The following is a description of a gene set: Sensory perception of taste Human Gene Set: REACTOME_SENSORY_PERCEPTION_OF_TASTE studied in species Homo sapiens, and this is the list of marker genes: GNB1, CALHM1, TAS2R39, GRM1, SCNN1D, TAS1R1, TAS2R41, TAS2R43, TAS2R16, ITPR3, GNB3, SCN9A (NCBI Gene Id 93955), TAS2R3, CALHM3, TAS2R13, TAS2R38, TAS2R14, SCN4B, TAS2R40, GNG13, TAS2R10, TAS2R20, PLCB2, TAS2R31, SCNN1B, TAS2R8, TAS1R3, SCN1B, TAS2R46, TRPM5, TAS2R30, KCNJ2 (potassium inwardly rectifying channel subfamily J member 2), SCN2A, TAS2R1 (taste 2 receptor member 1), TRPM4, GRM4, SCNN1G, TAS1R2, SCN2B, SCNN1A, TAS2R4, SCN3A, GNAT3, TAS2R50 (taste 2 receptor member 50), OTOP1, TAS2R7, TAS2R5